The following is a description of a gene set: from publication Chen Y, Wang X (PMID 31504780) Genes predicted to be targets of miRBase v22 microRNA hsa-miR-4687-5p in miRDB v6.0 with MirTarget v4 prediction scores > 80 (high confidence targets). species: Homo sapiens Human Gene Set: MIR4687_5P, and this is the list of marker genes: TSEN2, PURA, DGKI, CDK12, ANK1, LUZP1, CACNA1E, MEMO1, NLN, KCNJ16, CXCL5, BDKRB2, CASTOR3P, PEG10, VBP1, KLF6, CNKSR1, ZC3H7B, TLCD5, ELK4, AXIN2, ZNF609, SDR42E1 (short chain dehydrogenase/reductase family 42E, member 1), YAE1, ERC2, CELF2, GRM5, ELMO2, IGSF11, PPM1D, CPLX3, PHTF2, WDFY4, SLCO5A1, TMEM161B, TRIB1, SEC14L1, KLF3, SEC63, FAM220A, ATP2B4, ZKSCAN1, PRKCB, ZFAND6